Given this list of marker genes IMPDH2, NR4A2 (nuclear receptor subfamily 4 group A member 2), ANTXR2 (ANTXR cell adhesion molecule 2), MED12, ESCO2, GCH1, SYT1, here is a description of the gene set: Progressively worsening joint contractures. Progressive flexion contractures studied in species Homo sapiens Human Gene Set: HP_PROGRESSIVE_FLEXION_CONTRACTURES